The following is a description of a gene set: from publication Chen Y, Wang X (PMID 31504780) Human Gene Set: MIR3622A_3P_MIR3622B_3P species: Homo sapiens Genes predicted to be targets of miRBase v22 microRNA hsa-miR-3622a-3p, hsa-miR-3622b-3p in miRDB v6.0 with MirTarget v4 prediction scores > 80 (high confidence targets)., and this is the list of marker genes: ATXN1L, CAMKK2, KCMF1, NRIP1, CTNNA3, KLF6, SLC39A14, AFF2, ZNF705D, CLOCK, DCP2, SCML2, CHIC1, TMEM229B, FAM118A, SPTY2D1, XKR7, CFHR5, CLDN22, MAPK9, CMTM4, GDPD1 (glycerophosphodiester phosphodiesterase domain containing 1), SLC43A3, SPRY3, CHL1, SIPA1L2, PTPN12, SRSF2, DYNC2H1, CELF5, MYBL2, TXLNG, RIMS2, KIDINS220, C16orf95, STXBP5 (syntaxin binding protein 5, NCBI Gene Id 134957), TNPO1, SLC25A36, MBOAT2, PGGT1B, ZNF280B (NCBI Gene Id 23748), NAA30, AOC3, CSTF2T, MKNK2, ZBTB43 (NCBI Gene Id 90789), SOS2, RAB39B, PIK3CG, DPH3, LMBRD2, LY6K, MAP4K4, EXOSC3, HIPK3 (NCBI Gene Id 10114), UBN2, KRTAP2-4, INAFM2, ZNF148, SPATA13, KIAA1549L, C6orf62, ZNF268, GRIK4, PXMP2, S1PR5, STK38L, HIP1, TDRKH, PTPN1 (protein tyrosine phosphatase non-receptor type 1), RIMBP2, SETD5, NEUROD4, PAQR9, SH3TC2, FHL1, RCC2, BAHCC1, BACH1, UBE2D3 (NCBI Gene Id 7323), BEND4, PHLPP1, DPY19L3, LCOR, SV2B, ICE2, TMC7, BOK, MSANTD4, SLC35D1, PCSK2, HMOX2, ZMAT2, AMZ1, CABP5, SCRN3 (NCBI Gene Id 79634), GNB4, EPHA4 (NCBI Gene Id 401031), BACH2